Given this list of marker genes Cx3cr1, Hacd4, Jund, Eef1a1, Tmcc1, Klf2, Metrnl, Rgs2, Lyz2, Fau, Tnfrsf1b, Ifngr1, Samsn1 (SAM domain, SH3 domain and nuclear localization signals, 1), Cytip, Gpx1, Eef2, Naca, Ypel3, Nr4a1, Cybb, Sat1, Fosb, Otulinl, Arhgap45, Pou2f2, Rras, here is a description of the gene set: Cytokines mediate cell-cell communication in the immune system and represent important therapeutic targets. A myriad of studies have highlighted their central role in immune function, yet we lack a global view of the cellular responses of each immune cell type to each cytokine. To address this gap, the authors created the Immune Dictionary, a compendium of single-cell transcriptomic profiles of more than 17 immune cell types in response to each of 86 cytokines (>1,400 cytokine-cell type combinations) in mouse lymph nodes in vivo. A cytokine-centric view of the dictionary revealed that most cytokines induce highly cell-type-specific responses. For example, the inflammatory cytokine interleukin-1β induces distinct gene programmes in almost every cell type. A cell-type-centric view of the dictionary identified more than 66 cytokine-driven cellular polarization states across immune cell types, including previously uncharacterized states such as an interleukin-18-induced polyfunctional natural killer cell state. Mouse Gene Set: CUI_MONOCYTE_IL18_RESPONSE_DN Genes negatively differentially expressed in cell type: Monocyte upon treatment with cytokine: IL-18 in mouse lymph nodes in vivo. species: Mus musculus from publication Cui A, Huang T, Li S, Ma A, Pérez JL, Sander C, Keskin DB, Wu CJ, Fraenkel E, Hacohen N (PMID 38057668)